The following is a description of a gene set: Human Gene Set: HP_HEMATOLOGICAL_NEOPLASM Hematological neoplasm studied in species Homo sapiens Neoplasms located in the blood and blood-forming tissue (the bone marrow and lymphatic tissue)., and this is the list of marker genes: CD27, RPL35, PRKACB, IDH1, FLT3, RB1, BUB3, PRKACA, STAT3, HAVCR2, TAL1, USB1, SLX4, SH2B3 (NCBI Gene Id 10019), WAS, BUB1B, RPL11, RPL35A, SCN9A, RAD51C, RFWD3, PRKCD, FANCE, ADA, TET2, CASP10, STK4, FANCI, SPRED1, IGHG2, ANAPC1, CDKN2A, SOS1 (SOS Ras/Rac guanine nucleotide exchange factor 1), TP63, GINS1, DCLRE1C, NRAS, ASXL1, GFI1, CTC1, TNFSF12, ICOSLG, ADAR, RNU7-1, PTPRC, TAL2, BRCA1 (NCBI Gene Id 672), AAGAB, TNFRSF1B, CR2, POLE, MAGT1, RPS27, TINF2, RPL31, RPL26, FANCG, MALT1, RPS15A, SH2D1A, ETV6, TYROBP, PRF1, GBA1, BRAF (NCBI Gene Id 673), LRBA, IL2RG, RAG2, RPS14, FANCA, MEFV, TCF3, ADH5, FANCL, RRAS, SRP19, RAG1, CD70, SAMHD1 (NCBI Gene Id 25939), DYNC2LI1, HLA-DRB1, TNFRSF13C (TNF receptor superfamily member 13C), KIT (KIT proto-oncogene, receptor tyrosine kinase), UBE2T, MYC, TNFRSF9, NUP214, RPL15, MDM2, FANCM, BLM, FOXP1, THPO, GLI1, IGKC, NBN, RASA2, BCL2 (NCBI Gene Id 596), RAD51, RPS20, IKZF3, CALR (calreticulin), RNASEH2C, HAX1, TCF4, NSUN2, STS, CCND1, MCM4, HEATR3, TREX1, TP53, TSR2, PICALM, PIK3CA, RPS28, ITK, CHD7, SAMD9L, PIGL, ADA2, JAK2, CSF3R, CTLA4, SETBP1, BRD4, MRAS, SMARCD2 (NCBI Gene Id 6603), TNFRSF13B, EFL1, CD19, CD81, DIAPH1 (diaphanous related formin 1), RPS7, ALAD, CEP57, PMS2, IRF2BP2, XRCC4, TREM2, SCARB2, RIT1, SAMD9, ARHGAP26, PALB2, ERCC4, MAP2K1, PGM3, PIK3CD, MBD4, MAD2L2, SRSF2, STAT6, FANCF, SRP72 (signal recognition particle 72), CREBBP, RECQL4, NSD1, RPA1, CHEK2, DEF6, RHOH, UBA1, KIF11, SBDS, ZAP70, RAD54L, NPM1, NFATC2 (NCBI Gene Id 4773), RASGRP1, SOS2 (SOS Ras/Rho guanine nucleotide exchange factor 2), ABL1, WRN, IKZF1, TERC, BCL6, NAGS, PMS1, ATM, DNAJC21, LPP, PTPN11, SPRED2, CTPS1, RNASEH2A, F13B, GNB1, MYD88 (NCBI Gene Id 4615), FASLG, TRIP13, TTC7A, DNASE1L3, ICOS, CBL, TERT, EP300, EPCAM, GATA2, NHP2, NOP10, MPL (NCBI Gene Id 4352), RPS26, RNASEH2B, NUTM1, H4C9, BCL10, RNF43, ATRX (NCBI Gene Id 6475), RPL5, RAD54B, NFKB1, ELANE, LZTR1, PTEN, SCN10A, RARA, SOCS1, RPS24, BIRC3, PIK3R1, RTEL1 (NCBI Gene Id 53593), RPL27, PNP, CD28, RMRP, DUT, TYMS, TCIRG1, FCHO1, RAF1, BAX, RRAS2, CEBPA, SCN11A, BRIP1, F13A1, XIAP, NBEAL2, RUNX1, WIPF1, NF1, DKC1, RPS29, MS4A1, LSM11, FANCB, MLH1, APC, RPL9, NFKB2 (NCBI Gene Id 4791), HSCB, MSH2, KLHDC8B, HSPA9, BCR, ERBB3, SF3B1, BUB1, SH3GL1, SRP54, GATA1, KRAS, PARN, PTPN6, RPS10, FANCC, FANCD2, MSH6, APC2, RPL18, XRCC2, FAS, LIG4, RPS19, COL14A1, CLPB, MYSM1, EVC, PDGFRA, NAF1, EVC2, HLA-DQB1, MLLT10, TGFBR2, IL7R, WRAP53, RPS17, SMPD1, CHIC2, SMARCAL1, IFIH1, DNMT3A, BRCA2, HLA-DQA1, RPL8, DDX41, SYK, NTHL1